Given this list of marker genes Upf1, Gm7324, Rbmx, Rbmxl1, Adar, here is a description of the gene set: Mouse Gene Set: GOCC_SUPRASPLICEOSOMAL_COMPLEX species: Mus musculus Multicomponent complex of RNA and proteins that is composed of four active spliceosomes, termed native spliceosomes, connected to each other by the pre-mRNA. The supraspliceosome is the nuclear machine where the pre-mRNA processing takes place, like the 5'-end capping, 3'-end cleavage, splicing and editing.